Given this list of marker genes CD46, NR3C2, CFH, ASH1L, HELLPAR, NOS3, SPTBN1, CFI, MYT1L, here is a description of the gene set: Human Gene Set: HP_MATERNAL_HYPERTENSION Increased blood pressure during a pregnancy. Maternal hypertension studied in species Homo sapiens